The following is a description of a gene set: species: Homo sapiens Genes having at least one occurrence of the motif NNGTTGCWWGGYAACNGS in the regions spanning 4 kb centered on their transcription starting sites. This matches the MIF transcription factor binding site V$MIF1_01 (v7.4 TRANSFAC). Human Gene Set: MIF1_01, and this is the list of marker genes: FAM167A, TBC1D16, CCND2, MRPL10, GARRE1, NCOA5, PTDSS2, GMPR2, DHRS3, ELAPOR1, EFTUD2, CIMIP1, GTF3C4, SIK1, CDK20, BCL2L1 (NCBI Gene Id 598), CEP83, FGF13, NCDN, STMN4, JADE1, ORAI3, WARS2, NEDD9, ODAD3, ARID1A, SMC1B, THNSL1, PACRG, TBATA, ARL13B, LINC00649, SALL2, MADD, ENKD1 (enkurin domain containing 1), CCDC60, TEKT2, EFNB3, GPR119, DYDC2, KIF3B, PRKCSH, YWHAE (tyrosine 3-monooxygenase/tryptophan 5-monooxygenase activation protein epsilon), GRWD1 (NCBI Gene Id 83743), FGR, SAXO4, GALNT14, TP53BP1, DHX30, MED25, RNF41 (ring finger protein 41), CBLB, TUSC3 (NCBI Gene Id 7991), PRKN, C2CD2L, AP1M1, RASGEF1A, TTC12, WWP1, MYCBP, PNKD, STK36, SPTAN1, TPCN1, BMP6, TLX3 (NCBI Gene Id 30012), DIO3, PARP8, ADK, RUNX1T1, SDCBP2, ELAVL2, PDZD4, DNAL4, FUZ, DNAJC1, POLD4, DDX31, RNF25 (NCBI Gene Id 79103), CYTH2, SOX3, AKIRIN1, UBE2U, BDNF, EMX2, MDH1, CPEB2, CARS1, GRID2, PRR16, TMEM109, GFOD2, ERRFI1, GLRA3, MYO1C, CX3CL1, GRIK5, CIMIP6, MAP9, TGFB3, PLA2G12A, SMAD5, HMGCS1, PPME1, SOCS1, LINC01138, NAA20, REEP4 (receptor accessory protein 4), CRLF1, UBB, CIMIP2A, TCTN3, CDKL5, SOX5, TTC16, KCNRG, NEDD8, CBX4, FAM72A, CSMD3, VWA3B, HM13, SHANK2, DCTN1, KIF17, FILIP1, TMEM43 (NCBI Gene Id 79188), TRIM39, TBPL1, CCDC103, FASTKD2, TTC8, SREBF1, SLC25A37, FIBCD1, HAT1, SPPL2B, ITGB8, LRP2, SPRY2, JADE2, CHCHD4, DMD, DPAGT1, PTCH2 (NCBI Gene Id 8643), ZBTB48, CBX6, SIAE, CIBAR2, IQCD, FAM219A, PTCH1, LSM7, APH1A, VEGFA, RFX2, PLCB3, CCDC6, MDH1B, COQ8B, NAA60, BBS2, SPA17, NRGN, MAGED1, LRRC46, DYNLL1, NEK2, GRM3, TSC22D1, E2F5, APOBEC4, DNAI1, AZI2, ENKUR, LURAP1L, GPRC5D, RIBC2, DNAH7, NAT14, FAM76A, CD44, DNAH9, ARL4A, FHIP1B, NSMF